The following is a description of a gene set: Human Gene Set: BURTON_ADIPOGENESIS_8 Progressively down-regulated 8-96 h during differentiation of 3T3-L1 cells (fibroblast) into adipocytes. studied in species Mus musculus During cellular differentiation and development, it is recognized that many complex molecular mechanisms as well as precise patterns of differentially expressed genes occur in directing precursor cells toward a given lineage. Using microarray-based technology, we examined gene expression across the course of 3T3-L1 adipocyte differentiation. Total cellular RNA was isolated at times 0, 2, 8, 16, 24, 48, and 96 h following treatment with either standard hormonal inducers of differentiation; insulin, dexamethasone, isobutylmethylxanthine (IDX), or IDX plus trichostatin A (TsA), a histone deacetylase inhibitor and potent adipogenic inhibitor. cRNA was synthesized from cellular RNA and hybridized to high density Affymetrix MG_U74Av2 microarray gene chips containing 12,488 cDNA/Expressed Sequence Tags (ESTs) probe sets. From the IDX-only treated cells, all probe sets that were either unchanged or differentially expressed less than 2-fold throughout differentiation with respect to time 0 preadipocytes were excluded from further analyses. This selection resulted in a net of 1686 transcripts, 859 were increased in expression, and 827 were decreased in expression at least 2-fold across differentiation. To focus in on genes that were more specific to differentiation, the same analysis was performed on IDX plus TsA-treated non-differentiating cells and all probe sets from the IDX-only group that exhibited similar expression profiles in the non-differentiating TsA-treated group were excluded leaving a total of 1016 transcripts that were regulated only under differentiating conditions. Six hundred and thirty-six of these transcripts were elevated at least 2-fold and 380 exhibited a decrease in expression relative to time 0 preadipocytes. This group of genes was further analyzed using hierarchical clustering and self-organizing maps and resulted in the identification of numerous genes not previously known to be regulated during adipocyte differentiation. Many of these genes may well represent novel adipogenic mediators and markers of adipogenesis. from publication Burton GR, Nagarajan R, Peterson CA, McGehee RE Jr (PMID 15033539), and this is the list of marker genes: PTGIS, SCPEP1, GNB1, VCAM1, MYH9, TUBA1A, FXYD5, BDNF (brain derived neurotrophic factor), NSA2, PHLDB2, CD99, APP (amyloid beta precursor protein), PLTP, PRR13, HMGCR, RPS6KA4, SLC38A4, LEPROT, TAPBP, LAMP2, MATN4, ASAH1, KCTD10, NCAM1, EMP3, SPTAN1, CAPG, SERTAD1, SMAD6, PRDX4, ZFP36L2, SERPINB6, PDPN, LOX, MAPKAPK2 (MAPK activated protein kinase 2), SKI, FGF7, FAM91A1, PLXNB2, DSTN, PLA2G7, PRAF2, PDLIM7, MSN, ANXA3 (NCBI Gene Id 306), CTSA, TSPAN6, SERPINF1, RAB31, ACTA2, COL4A5, SLC1A4, USP22, EMP1, GNG10, KDELR3, CMTM3, B9D1, MAP1LC3B, PLD3, GSTM1, CAP1, TCEAL9, OGN, CPQ, VCL, TWIST2, ITGAV, GBA1, PSAP, PRSS23, F2R, TPBG, DAXX, TMSB10, BAX, TES, CD276, SLC7A5, ANXA5